Given this list of marker genes Pkd2, Calb1, Wt1, Foxj1, Lhx1, here is a description of the gene set: Mouse Gene Set: GOBP_METANEPHRIC_PART_OF_URETERIC_BUD_DEVELOPMENT The development of the portion of the ureteric bud tube that contributes to the morphogenesis of the metanephros. species: Mus musculus